The following is a description of a gene set: Human Gene Set: DESCARTES_FETAL_LUNG_LYMPHOID_CELLS studied in species Homo sapiens from publication Cao J, O'Day DR, Pliner HA, Kingsley PD, Deng M, Daza RM, Zager MA, Aldinger KA, Blecher-Gonen R, Zhang F, Spielmann M, Palis J, Doherty D, Steemers FJ, Glass IA, Trapnell C, Shendure J (PMID 33184181) Marker genes curated from the annotated cluster as represented in the Descartes Human Gene Expression During Development database. The gene expression program underlying the specification of human cell types is of fundamental interest. The study authors generated human cell atlases of gene expression and chromatin accessibility in fetal tissues. For gene expression, the study authors applied three-level combinatorial indexing to >110 samples representing 15 organs, ultimately profiling ~4 million single cells. The study authors leveraged the literature and other atlases to identify and annotate hundreds of cell types and subtypes, both within and across tissues. Our analyses focused on organ-specific specializations of broadly distributed cell types (such as blood, endothelial, and epithelial), sites of fetal erythropoiesis (which notably included the adrenal gland), and integration with mouse developmental atlases (such as conserved specification of blood cells). These data represent a rich resource for the exploration of in vivo human gene expression in diverse tissues and cell types., and this is the list of marker genes: FCRL1, ZNF683, ZAP70, RASGRP1, NCR3, AGMAT (agmatinase (putative)), LTA, CD160, PYHIN1, SHISAL2A, VPREB3, S1PR4, NKG7, KLRC3, VAV3-AS1 (VAV3 antisense RNA 1), MEOX1, VPREB1, LINC00426, CDHR1, TNFRSF9, GZMK, IGHM, IL2RA, PRF1, SAMD3, IGHD, XCL1, CTLA4, ITK, SLAMF1, IL2RG, STAT4, SEPTIN1, GPR171, CR2, CD3G, NCR1, CCR7, FOXP3 (NCBI Gene Id 50943), CHI3L2, APOBEC3D, TIGIT, GZMB, CRTAM, GZMA, TRBC2, KLRC1, CHRM3-AS2, S1PR5, ENSG00000267568, NPM1P27, KLRB1, FLT3LG, CD8B, FCRL5, TCL1A (TCL1 family AKT coactivator A), C10orf88B, KLRK1, CORO1A, TNFRSF13B, GZMM, CD27, PTPRCAP, FCMR, TBC1D10C, ENSG00000266088, CD19, ENSG00000224610, IL7R (NCBI Gene Id 3575), PSMA8, JCHAIN, NPM1P7, PDCD1, DGKA, MS4A1, CD2, SIT1, ANTXRLP1, TBX21, TRGC1, SH2D1A, TMIGD2, CD3D, UBASH3A, MZB1 (marginal zone B and B1 cell specific protein), LINC02325, IGLL5, LY9, GNLY, IFNG-AS1, FCRLA, PAX5, ICOS, CD247, CXCR6, FASLG, IGKC, SIRPG, TXK, KLRC4-KLRK1, TRGC2, RHOH, CD8A, TCF7, LINC02273, IL18RAP, CD5, TRDC, ENSG00000227863, CD7, THEMIS, STAP1, MATK, SKAP1, STK17A, CXCR5, CXCR3 (C-X-C motif chemokine receptor 3), LINC01215, IL23R, GPA33, IL2RB, LEF1, CST7, SLC14A1, ENSG00000259097 (novel transcript), XCL2, CD3E, KLRF1, LTB, IKZF3, CD79A, CD52, CA6, SCML4, SLAMF6, PTGDR, GZMH, SH2D1B, LINC01934, P2RX5, LAX1, TRAT1, LINC00861, RAG2, ZBP1, KLRC2, LINC01891, NT5C3AP2, SATB1-AS1 (SATB1 antisense RNA 1), FCRL2, NIBAN3, FCRL3, TRD-AS1, IGLL1, LCK, LINC01222, BLK, LINC01259, DNTT, CD79B, LEF1-AS1, PCED1B-AS1